The following is a description of a gene set: Human Gene Set: GOBP_REGULATION_OF_ENDOCYTIC_RECYCLING Any process that modulates the frequency, rate or extent of endocytic recycling. species: Homo sapiens, and this is the list of marker genes: MTMR4, EHD1, ZDHHC2, INPP5F, PLA2G4E, RAB11A, PLA2G3, AKAP5, BVES, EIPR1, NDRG4, EHD2, ARHGAP44, RAB11FIP3, ATP9A, SORL1, COMMD1, ACTN2, ARHGAP1, RAB11B, GRIPAP1, ARHGAP8